The following is a description of a gene set: PMS2 heterodimerizes with MLH1 to form the MutL alpha complex involved in DNA mismatch repair. Mutations in this PMS2 are associated with hereditary nonpolyposis colorectal cancer, Turcot syndrome, and are a cause of supratentorial primitive neuroectodermal tumors. Heterozygous truncating mutations in PMS2 play a role in a small subset of hereditary nonpolyposis colorectal carcinoma (Lynch syndrome, HNPCC-like) families. PMS2 mutations lead to microsatellite instability with carriers showing a microsatellite instability high phenotype and loss of PMS2 protein expression in all tumors. part of: Diseases of Mismatch Repair (MMR) Reactome Pathway: Defective Mismatch Repair Associated With PMS2 studied in species Homo sapiens, and this is the list of marker genes: PMS2, MLH1